Given this list of marker genes UROC1, LARS1, ADI1, GAD2, AUH, HYKK, KMO, DARS1, SLC38A8, ASNS, PARK7, PIPOX, AASS, MCCC2, GGT5, KYAT1, ADHFE1, ADSS1, PCCA, TPH2, ALDH6A1, BPHL, ART4, HDC, CARNS1, GLUL, NR1H4, MAT1A, AADAT, CARS2, LGSN, SEPHS2, ASPG, BCAT1, ADSS2, PM20D1, DAOA, GLDC, PSAT1, SLC25A2, EGLN2, KYAT3, MMUT, MTHFR, IL4I1, BHMT2, MPST, PRODH, DDO, DDC, VARS2, MTHFD2L, ARHGAP11B, GSTZ1, WARS1, PRODH2, NAGS, PLOD2, BAAT, SEPHS1, HNF4A, ACCS, AGXT, IDO1, MARS2, GLYATL1, SDS, EPRS1, MTHFD1, ACADSB, PAH, DIO1, IDO2, P4HB, IARS2, OCA2, TYR, TDO2, EARS2, HAL, HPD, PPM1K, TPH1 (tryptophan hydroxylase 1), KARS1, SMS, MRI1, WARS2, GCAT, GARS1, HMGCLL1, DPYD, BLOC1S6, BHMT, HSD17B10, HARS2, DGLUCY, ECHS1, FH (NCBI Gene Id 83748), ALDH1A1, NAT8L, ARG2, DLST, TARS1, PARS2, ALDH8A1 (aldehyde dehydrogenase 8 family member A1), AMDHD1, TAT, HAO1, GPT2, PHGDH, ATP2B4, SLC39A8, GATB, TH, CPS1, HOGA1, OTC, MIR21, GGT1, ACY1, RARS2, SLC1A3, ASRGL1, ACAD8, AGMAT, LARS2, GAD1, MARS1, DPEP1, VARS1, THAP4, GSS, GLYATL1B (NCBI Gene Id 100287520), LRRC47, ARG1, SHMT2, HIBADH, GLYAT, GCDH, ASL (NCBI Gene Id 435), SDSL, BCKDK, ACCSL, CARNMT1, SIRT4, UCP2, NOS1, PSPH, GOT1, DLD, CARS1, UPB1 (beta-ureidopropionase 1), IYD, DDAH2, FTCD, ENSG00000274276, SLC25A21, MTHFS, GCLM, ETFA, CRYM, SERINC5, DBT, ATP7A, PTS, NOX4, QRSL1, NARS2, ALDH4A1, PFAS, HARS1, ICMT, YARS2, FARSA, SLC25A44, AMT, APIP, RIDA, SLC7A11, DCT, PLOD3, DALRD3, QDPR, FARS2, PCCB, AASDH, GCSH, BCAT2, ENOSF1, SCLY, SHMT1, RARS1, HPDL, ACAT1, HMGCL, GLS2, ALDH5A1, ETFB, NOS3, CAD, ALDH18A1, NDP, RIMKLB, ATF4, SARS1, PYCR2, CTNS, GLUD1, FAH, MTRR, SLC38A1, HIBCH, ABAT, AZIN2 (NCBI Gene Id 113451), NIT2, THNSL2, CDO1, SARS2, ATCAY, HAAO, CSAD, GOT2, ODC1, TARS3, IVD, AGXT2, TTC36, DARS2, MSRA, ASS1, PYCR1, YARS1, BCKDHB, NARS1, NOS2, HNMT, PYCR3, KYNU, SLC45A2, PCBD1, ASNSD1, ENOPH1, MCCC1, PEPD (peptidase D), CTH, BCKDHA, MTR, DAO, SERINC3, AARS2 (alanyl-tRNA synthetase 2, mitochondrial), HGD, CLN3, SARDH, GLS, MECP2, GNMT, CBS, ACMSD, GPT, NOXRED1, SLC16A2, OAT, FARSB, SLC7A7, SRR, AZIN1, NADSYN1, AFMID, GLUD2, ASPA, IARS1, GCLC, AARS1, RIMKLA, DDAH1, GOT1L1, BLMH, FPGS, TARS2, QARS1, GATC, AARSD1, here is a description of the gene set: studied in species Homo sapiens Human Gene Set: GOBP_AMINO_ACID_METABOLIC_PROCESS The chemical reactions and pathways involving amino acids, carboxylic acids containing one or more amino groups.